Given this list of marker genes C8orf44, SCLT1, ELOC, PDE5A, GPR17, DYNC1I2, GPRC5B (G protein-coupled receptor class C group 5 member B), YRDC, C18orf63, ZNF195, SNW1, BLID, AEBP2, RAB11FIP1, TBX18, PROSER1, MGST2, CRPPA, ISCU, BTF3L4, FOXJ2, MTRR, CHAC1, GAPT, ZDHHC9, PRKD3, ZNF664 (zinc finger protein 664), SDR16C5, CDKL4, DCX, DCC, PICALM, CDC6, PGR, ALDH1A2, HOMER1, KRT40, ARFGEF1, RPP30, here is a description of the gene set: Genes predicted to be targets of miRBase v22 microRNA hsa-miR-3115 in miRDB v6.0 with MirTarget v4 prediction scores > 80 (high confidence targets). species: Homo sapiens Human Gene Set: MIR3115 from publication Chen Y, Wang X (PMID 31504780)